Given this list of marker genes Gtf2h5, Lekr1 (leucine, glutamate and lysine rich 1), Cdr1, C3ar1, Tubgcp4, Nsd2, Mtcp1, Elovl1, Slc15a2, Gk5, Cyp4v3, Zfp850, Ropn1, Zfp106, Myl12a, Kcne3, Asic2, Esrrg (estrogen-related receptor gamma), Nedd9, Nim1k, Ddx19b, Epm2aip1 (NCBI Gene Id 77781), Fam135a, Thy1, Napg, Epdr1, Pnp, Rd3, Tmem167, Pnpla8, Ermap, Dlc1, Coro1b, Slc5a8, Cetn1, Zfp217, Cpeb4, Bckdhb, Fbxo11 (NCBI Gene Id 98072), Hmbs, Trib2, Tfrc, Clec4b2 (C-type lectin domain family 4, member b2), Ppp6r1, Tafa1 (NCBI Gene Id 320265), Scn1a, Naa50, Cdkn1b, Dtwd2, Dennd1b, Pigk, Itprid2, Skida1, Pdcd6ip, Sgk1, Eef1b2, Prr11, Fastkd2, Arpc1a, Ppp4r3c2, Slc2a1, Fbxl16, Kdm7a, Slc36a4, Lamp3, Calhm5, Mettl9, Mctp1, Man2a1, Camk1, Ppp4r2, Ccdc85a, Camta1, Wnt5a, Garre1, Zfp449, here is a description of the gene set: species: Mus musculus from publication Chen Y, Wang X (PMID 31504780) Mouse Gene Set: MIR_141_5P Genes predicted to be targets of miRBase v22 microRNA mmu_miR_141_5p in miRDB v6.0 with MirTarget v4 prediction scores > 80 (high confidence targets).